Given this list of marker genes ATG5, NLRP6, ALOX12B, ADA, CYBA, ADORA1, P2RY2, PRKCE, here is a description of the gene set: Human Gene Set: GOBP_REGULATION_OF_MUCUS_SECRETION studied in species Homo sapiens Any process that modulates the frequency, rate or extent of the regulated release of mucus from a cell or a tissue.